The following is a description of a gene set: Genes down-regulated in pancreatic CD8 T cells from mice with: type 1 diabetes mellitus versus healthy controls. from publication Lee JS, Scandiuzzi L, Ray A, Wei J, Hofmeyer KA, Abadi YM, Loke P, Lin J, Yuan J, Serreze DV, Allison JP, Zang X (PMID 22972920) Human Gene Set: GSE40225_WT_VS_RIP_B7X_DIABETIC_MOUSE_PANCREATIC_CD8_TCELL_DN studied in species Homo sapiens B7x (B7-H4 or B7S1) is the seventh member of the B7 family and the in vivo function remains largely unknown. Despite new genetic data linking the B7x gene with autoimmune diseases, how exactly it contributes to peripheral tolerance and autoimmunity is unclear. Here we showed that B7x protein was not detected on antigen-presenting cells or T cells in both human and mice, which is unique in the B7 family. As B7x protein is expressed in some peripheral cells such as pancreatic b cells, we utilized a CD8 T cell-mediated diabetes model (AI4ab) in which CD8 T cells recognize an endogenous self-antigen, and found that mice lacking B7x developed more severe diabetes than control AI4ab mice. Conversely, mice overexpressing B7x in the b cells (Rip-B7xAI4ab) were diabetes free. Furthermore, adoptive transfer of effector AI4ab CD8 T cells induced diabetes in control mice, but not in Rip-B7xAI4ab mice. Mechanistic studies revealed that pathogenic effector CD8 T cells were capable of migrating to the pancreas but failed to robustly destroy tissue when encountering local B7x in Rip-B7xAI4ab mice. Although AI4ab CD8 T cells in Rip-B7xAI4ab mice and AI4ab mice showed similar cytotoxic function, cell death, and global gene expression profiles, these cells had greater proliferation in AI4ab mice than in RIP-B7xAI4ab mice. These results suggest that B7x in nonlymphoid organs prevents peripheral autoimmunity partially through inhibiting proliferation of tissue-specific CD8 T cells and that local overexpression of B7x on pancreatic b cells is sufficient to abolish CD8 T cell-induced diabetes., and this is the list of marker genes: SRPK1, SND1, NCAPH, NOA1, H2BC6, MARVELD2, GAPDH, TWSG1, ALG9, IDH3G, SSR4, CYFIP1, TRIM47, OPTN, UCHL5, COPB1, MDM2, CACNB3, DUSP16, MCRS1, TOP1, HDGF, SRP68, H2BC10, PTTG1, FHIP2A, SLC35E1, MANF, AARS1, HMGB2, H4C4, MTRR, UBXN6, FTSJ1, BIN2, KIF4A, SLC17A9, METTL1, MAN2A1, GEMIN7, BRCA1, SLC35C1, SLC12A4 (NCBI Gene Id 6560), SLC2A8, PMVK, ZNRD2, SKA1, DEPTOR, KNTC1, COX18, PGM3, MCAT, PLK4, MARS1, RANBP3, CENPI, EDRF1, CKS2, IGHV4OR15-8 (NCBI Gene Id 388078), RBM47, CCNE2, POU2AF1, IRF7 (interferon regulatory factor 7), SLFN11, MT2A, PIEZO1, UBE4A, ARHGDIA, ENSG00000237250, NDUFB7, IARS1, EIF2AK3, YIF1B, ACOX1 (acyl-CoA oxidase 1), PSEN2 (NCBI Gene Id 5664), MFSD2A, H3C10, KLHDC4, PTPN1, LIN52, ZNF215, UBE2J1 (ubiquitin conjugating enzyme E2 J1), LZTFL1, H3C11, SPC24, RINT1, HMOX2, BSG, CENPA, H2AZ1, PAM, PMM2, SEPHS1 (NCBI Gene Id 88214), FRRS1, PKP4, FBXW8, GALNT1 (NCBI Gene Id 2589), CLDND1, H2AC4, BAK1, CACNB1, TPRG1, UBE2S, NEIL3, MLEC, ECH1, AIFM1, TMED3, MT1H, MYCBP, IDE, NAGLU (NCBI Gene Id 4669), TUBG1, IQGAP2, SLFN13, TICRR, USO1, CDIPT, MAD2L1, H2AC8, MAPKAPK3, CAMKK2, SRP72, TFDP1, LINC02363, SDF2L1, NECAB3, NFXL1, CTSV, MRPL4, BSCL2, PSMA5, CDC25A, ATG13, BUD23, XK, ARF4, N4BP2, MLKL, PRC1, MDFIC, ZC3HAV1L, AAAS, IGF1, ADRM1, RTRAF, JTB, SPTY2D1, ECT2, AGPS, PYGB, IFNAR1, ALG5, ALDH18A1, PLD3, BMP6, ZDHHC9, POMP, SOS1, MLST8, KTI12, ENO1, CABLES1, MAN2B1, PLEKHA7, NCALD, PIK3C2A, RDX, LTK, ECHS1, DAXX, JPT1, DENND1B, RAB39B, BCAR3 (NCBI Gene Id 8412), SESN2, OAS1, GBA1, MDH2, GBF1, GPN2, CHST2 (NCBI Gene Id 96111), NOD2 (nucleotide binding oligomerization domain containing 2), TMEM184B, UAP1, CRIP1, PIM1, NFIL3, ATOSB, SCAMP2, PDXDC1, PSMD9 (proteasome 26S subunit, non-ATPase 9), C20orf96, ARFGAP3, CDCA4, KCNN3, ALG14, BMP8A (bone morphogenetic protein 8a), ULK2, PPAT